The following is a description of a gene set: Human Gene Set: WP_CHOLESTEROL_BIOSYNTHESIS_PATHWAY_IN_HEPATOCYTES studied in species Homo sapiens Cholesterol biosynthesis pathway in hepatocytes, and this is the list of marker genes: HSD17B2, CYP21A2, EBP, CYP2R1, HSD17B12, HSD17B11, ERG28, OSBPL7, SCP2, ABCA1, ACOT8, SLC27A2, MYLIP, DHCR7, CYP51A1, CYP3A7, HMGCS1, PRKAA2, GGPS1, CH25H, MVD, CYP19A1, ACSL1, ELOVL3, ACBD3, DHRS11, OSBPL6, ABCB11, HSD17B7, FDX1, IDI1, CYP17A1, TM7SF2 (NCBI Gene Id 7108), ACAT2, OSBPL1A, SCP2D1, SLC27A5, SRD5A2, HINT2, CYP46A1, HMGCR, OSBPL3, PMVK, CYB5R1, LSS, SRD5A1, FADS2, CYP7A1, PBX1, SLC22A24, HSD3B1, MSMO1, CYP11A1, RDH8, FDXR, STAR, ABCG1, ELOVL5, BAAT, HSD3B2, HSD17B3, CYP11B1, ACOT1 (NCBI Gene Id 641371), ELOVL4, ELOVL2, HSD17B1, LBR, HSD17B8, CYP39A1, AKR1D1, ACOT2, OSBPL2, CYP27A1, HSD3B7, ABCD3, CYP7B1, ACSL3, DHCR24, FDFT1, SDR42E2, SREBF1 (NCBI Gene Id 6720), HSD17B10, FDPS, PRLR, MVK, NR1H3, SERINC1, CLIP3, CYP27B1, PRKAA1, PCSK9, CYB5R3 (NCBI Gene Id 1727), AKR1C4 (NCBI Gene Id 1109), CYB5R2, IDI2, CYP11B2 (cytochrome P450 family 11 subfamily B member 2), NR1H2, SCD, TSPO, CYP8B1, AMACR, HMGCS2, CYP3A4, CYP1A1 (NCBI Gene Id 1543), PLPP6, HNF1A, OSBP, SDR42E1, OSBPL9, NSDHL, SC5D